Given this list of marker genes Uros, Folr2, Mtr, Slc46a1, Mthfs, Ftcd, Izumo1r, Sardh, Gnmt, Dmgdh, Slc19a1, Tyms, Mthfsl, Dhfr (dihydrofolate reductase), Folr1, here is a description of the gene set: studied in species Mus musculus Mouse Gene Set: GOMF_FOLIC_ACID_BINDING Binding to folic acid, pteroylglutamic acid. Folic acid is widely distributed as a member of the vitamin B complex and is essential for the synthesis of purine and pyrimidines.